Given this list of marker genes Lilra6, Pira12, Lilra5 (NCBI Gene Id 232801), Pira13, Pira2, Pirb, here is a description of the gene set: Combining with a MHC class I protein complex to mediate signaling that inhibits activation of a lymphocyte. studied in species Mus musculus Mouse Gene Set: GOMF_INHIBITORY_MHC_CLASS_I_RECEPTOR_ACTIVITY